Given this list of marker genes PRSS37, SPINK13, ZP4, PLB1, PLA2G10, PKDREJ, IQCF1, PLCB1, HVCN1, SPINK1, SERPINA10 (NCBI Gene Id 51156), CCDC87, B4GALT1, CRISP1, FAM170B, ZP3, GLRA1, CACNA1H (NCBI Gene Id 8912), ZP2, here is a description of the gene set: species: Homo sapiens Human Gene Set: GOBP_REGULATION_OF_ACROSOME_REACTION Any process that modulates the frequency, rate or extent of the acrosome reaction.